Given this list of marker genes TNFAIP2, ANPEP (NCBI Gene Id 290), NRG1, JAG1, VEGFD, NRP1, MFNG, FGF1, TNFSF12, PBX3, VEGFC, CXCL8, ANGPT1, FGF2, FGF6, IL18, EPAS1, KDR, TBXT, PTPRR, MMP19, here is a description of the gene set: Human Gene Set: MODULE_362 Angiogenesis. species: Homo sapiens